The following is a description of a gene set: Aside from Myc-activating translocations characteristic of plasmacytomas (PCT), little is known about genetic factors and signaling pathways responsible for the development of spontaneous B-cell lineage lymphomas of mice. Here, we characterized the transcriptional profiles of PCT, centroblastic diffuse large B-cell lymphomas (CBL), and high-grade splenic marginal zone B-cell lymphoma (MZL++) using high-throughput quantitative reverse transcription-PCR. Expression profiles of CBL and MZL++ were strikingly similar and quite unlike that of PCT. Among the genes expressed at significantly higher levels by PCT were a number involved in NOTCH signaling, a finding supported by gene set enrichment analyses of microarray data. To investigate the importance of this pathway, NOTCH signaling was blocked in PCT cell lines by treatment with a gamma-secretase inhibitor (GSI) or transduction of a dominant-negative mutant of MAML1. These treatments resulted in reduced expression of NOTCH transcriptional targets in association with impaired proliferation and increased apoptosis. GSI treatment of transformed plasma cells in a primary PCT also induced apoptosis. These results integrate NOTCH activation with oncogenic signaling pathways downstream of translocated Myc in the pathogenesis of mouse PCT, two signaling pathways also implicated in development of human multiple myeloma and T-cell lymphoblastic lymphoma. Cluster 7 of genes distinguishing among different B lymphocyte neoplasms. Mouse Gene Set: SHIN_B_CELL_LYMPHOMA_CLUSTER_7 from publication Shin DM, Shaffer DJ, Wang H, Roopenian DC, Morse HC 3rd (PMID 19010892) studied in species Mus musculus, and this is the list of marker genes: Ptch1, Rb1, Dkk4, Traf4, Zfp36 (NCBI Gene Id 22695), Dicer1, Bad, Apc, Notch3, Notch4, Tep1, Gsk3b, Max, Igf1r, Stat6, Bcl6, Gli2, Tert, Rarg, Pml, Dvl3, Il6st, Xrcc3, Cdkn1c, Pten, Dvl1, Wnt4